The following is a description of a gene set: from publication Chen Y, Wang X (PMID 31504780) Genes predicted to be targets of miRBase v22 microRNA hsa-miR-6501-5p in miRDB v6.0 with MirTarget v4 prediction scores > 80 (high confidence targets). species: Homo sapiens Human Gene Set: MIR6501_5P, and this is the list of marker genes: RCOR1, PRR11, ALCAM, NSUN7, SMG1 (SMG1 nonsense mediated mRNA decay associated PI3K related kinase), ABCC4, FBXW5, ALKBH4, PGM2L1, PHF6, ZCCHC14, UTP15, ZBTB18, BEND6, CRB1, APBB2, PTPN5, PREP, TRIM60, FAM162B, ABHD15, ZFP14, RTL3, TMOD2, SEMA6D, HLF, STK39 (NCBI Gene Id 27347), ZNF365, ADRA1A, UGT8, HSPA4L, RNPS1, RBCK1, EML4, FABP7, EPB41, NR1H4, KRT3, PELI3, ZC3H12C, KDM6A, PTEN, FAM47B, BAIAP2, AZIN1, TRERF1, SH3BGRL3, FOXG1, USP30, TAFA1, ASAP1, EPS15, PPP2R1B (NCBI Gene Id 5519), EDN3, ADAMTSL3, FAM47A, KLHL14, PHF2, TRUB1, MFSD14B, METAP2, DAB1, VEGFA, AEBP2, FBXO40, TMED7, AMPD3, CADM2, MIB1, RBM11, PTPRJ, KDELR2